The following is a description of a gene set: species: Homo sapiens Neighborhood of DAP Human Gene Set: MORF_DAP Neighborhood of DAP death-associated protein in the MORF expression compendium, and this is the list of marker genes: BCAP31, NDUFS1, SF3B2, FAM120A, PSMD8, CSNK2B, SUMO1, SDHA, AP3S1, PPM1G, COPE, HADHA, GGCT, SEM1, SSR4, DCTN2, AP2S1, SMARCD2, VBP1, CALM3, KPNA2, LSM3, ATP6V1A, LSS, RAC1, DAP, SEC24C (SEC24 homolog C, COPII coat complex component), PTOV1, NDUFS8, NSDHL, SOD1, IDH3G, TECR, DHCR7, PSMB2, GLB1, MDH1, PPP1CA, ATP6AP1, VPS26A, GDE1, KARS1, ENSA, SMG7, DDOST, PDCD6, RAD23B, CANX, SYPL1, TMED2, SKP1, AKR7A2, NDUFC1, UBE4A, PPP2R1A, PSMD9, MAML1, SREBF1, GPX4, MPV17, TRAPPC3, ARF3 (NCBI Gene Id 377), HADHB, YWHAB, TRIM28, KDELR1, CLTA, ERP29, ARF4, PRDX3, WBP2, COPS5, SLC35A1, TMBIM6, SEC13, F8A1, MTDH, GANAB